Given this list of marker genes Pex1 (NCBI Gene Id 71382), Pex2, Pex10, Pex5 (peroxisomal biogenesis factor 5), Pex6, Usp9x, Pex12, here is a description of the gene set: Mouse Gene Set: GOBP_PROTEIN_IMPORT_INTO_PEROXISOME_MATRIX_RECEPTOR_RECYCLING studied in species Mus musculus The process in which peroxisome targeting sequence receptors dissociates from cargo proteins and are returned to the cytosol.